Given this list of marker genes PSENEN, CDH3, CTNND1, IFNG (NCBI Gene Id 3458), KRT16, POFUT1, KRT6B, CDH1, KRT17, KRT6A, MNX1, POGLUT1, CEP57, TSC1, APC, EXTL3, TSC2, KRT5, ANTXR1, here is a description of the gene set: Nontender, round and firm, but slightly compressible, intradermal or subcutaneous cyst measuring 0.5-5 cm in diameter. Epidermal cysts are intradermal or subcutaneous tumors, grow slowly and occur on the face, neck, back and scrotum. They usually appear at or around puberty, and as a rule an affected individual has one solitary or a few cysts. Human Gene Set: HP_EPIDERMOID_CYST Epidermoid cyst species: Homo sapiens